The following is a description of a gene set: from publication Chen Y, Wang X (PMID 31504780) Mouse Gene Set: MIR_224_3P Genes predicted to be targets of miRBase v22 microRNA mmu_miR_224_3p in miRDB v6.0 with MirTarget v4 prediction scores > 80 (high confidence targets). studied in species Mus musculus, and this is the list of marker genes: Agbl4, Specc1l, Ubfd1, Ccdc178, Pdcl, Zfp24, Trim52, Senp6, Ankrd33b, Prpf40a, Prrx1, H2-M3, Mat2a, Pyurf, Rbbp6, Acsl3, Epcip, Arhgef38, Map1b, Nkain3, Snap47, Fbxo11, Trim24, Bpnt2, Scn3a, Exoc2, Skil, C1qtnf3, Zfp142, Ppfia2, Gpd2, Jag1, Cnot6l, Wnt11, Mef2a, Cadm4, Gigyf2, Ppp1r3a